The following is a description of a gene set: The process in which the developmental fate of a cell becomes restricted such that it will develop into a stem cell. Human Gene Set: GOBP_STEM_CELL_FATE_COMMITMENT species: Homo sapiens, and this is the list of marker genes: SFRP1, SOX18, EDN1, WNT8A, SOX9, GSC, EDNRA, SOX17, DMRTA2, SFRP2